The following is a description of a gene set: from publication Cui A, Huang T, Li S, Ma A, Pérez JL, Sander C, Keskin DB, Wu CJ, Fraenkel E, Hacohen N (PMID 38057668) Genes negatively differentially expressed in cell type: cDC1 (conventional dendritic cell type 1) upon treatment with cytokine: PSPN in mouse lymph nodes in vivo. species: Mus musculus Cytokines mediate cell-cell communication in the immune system and represent important therapeutic targets. A myriad of studies have highlighted their central role in immune function, yet we lack a global view of the cellular responses of each immune cell type to each cytokine. To address this gap, the authors created the Immune Dictionary, a compendium of single-cell transcriptomic profiles of more than 17 immune cell types in response to each of 86 cytokines (>1,400 cytokine-cell type combinations) in mouse lymph nodes in vivo. A cytokine-centric view of the dictionary revealed that most cytokines induce highly cell-type-specific responses. For example, the inflammatory cytokine interleukin-1β induces distinct gene programmes in almost every cell type. A cell-type-centric view of the dictionary identified more than 66 cytokine-driven cellular polarization states across immune cell types, including previously uncharacterized states such as an interleukin-18-induced polyfunctional natural killer cell state. Mouse Gene Set: CUI_CDC1_PERSEPHIN_RESPONSE_DN, and this is the list of marker genes: Fos, Rgs2, Jun, Zfp36, Atp5me, Nr4a1, Pmaip1, Atf3, Dusp1, Jund, Ier5, Kctd12